The following is a description of a gene set: Mouse Gene Set: GOBP_PROTEIN_K48_LINKED_UBIQUITINATION studied in species Mus musculus A protein ubiquitination process in which a polymer of ubiquitin, formed by linkages between lysine residues at position 48 of the ubiquitin monomers, is added to a protein. K48-linked ubiquitination targets the substrate protein for degradation., and this is the list of marker genes: Trim65, Ppia, Trim25, Tcf25, Ube3c, Hace1, Trim21, Rnf6, Anapc11, Ubr5, Ube2a, Znrf2, Cdc27, Anapc4, Anapc13, Peli1, Ubr4, Anapc7, Ube2g2, Anapc16, Trim55, Ube2e2, Rnf170, Ube2c, Btrc, Cdc26, Huwe1, Cdc23, Arih2, Ube2q2, Anapc5, Kcmf1, Trim44, Kbtbd7, Rnf187, Znrf1, Tnfaip3, Rbx1, Ube2e1, Gabarap, Cdc34, Spsb3, Anapc1, Mycbp2, Ube2t, Dtx4, Ube2e3, Dtx3l, Ube2g1, Rnf34, Skp1, Ube2d1, Rnf126, Ube2h, Trim31 (NCBI Gene Id 224762), Anapc15, Rnf5, Kbtbd6, Birc2 (NCBI Gene Id 77616), Skp2, Ttc3, Cul3 (NCBI Gene Id 98674), Marchf6, Rnf146, Cul1, Amfr (autocrine motility factor receptor), Anapc15-ps, Syvn1, Rnf216, Ube2d2b, Cdc34b, Nmi, Fbxo38, Ube2d3, Rnf8 (ring finger protein 8), Kbtbd2, Nt5c2, Fbxo7, Ube3a, Rffl, Cdc16, Ube2k, Rnf4, Rbx1-ps, Anapc10, Fbxo9, Nedd4l, Ube2q2l (ubiquitin conjugating enzyme E2 Q2 like), Rnf115, Prkn, Trim38, Ube2r2, Itch, Trim6, Ube2d2a, Trim45, Bfar, Topors, Ube2b, Fbxo45, Klhl3, Rnf152, Anapc2